Given this list of marker genes KMT2D, FGFR3, UBB, GLB1, PEX6, IPO8, TH, NEUROD2, NDUFV2, RMND1, STT3B, ACSF3 (NCBI Gene Id 197322), TSEN15, TRMT10C, B9D1, SMPD1, WNK1, TAF6 (TATA-box binding protein associated factor 6), MECP2, DHDDS, LIFR, SCNN1G, DHX30, PIGT, COG1, GNB1, ATP5F1A, ALDH18A1, HYLS1, TXNL4A, NEB, NKX2-1, GLE1, FOCAD (focadhesin), COL4A6, GALNT2, YARS1, DTYMK, ERCC8, TNNT1, PEX13, EPM2A, SLC38A3, CC2D2A, SUPT16H, SOX4, SON, SLC16A2, CACNA1S, OTUD5, IFIH1, POLA1, CEP120, PEX11B, SZT2, AIFM1, MTOR, NDE1, ATP1A3, IFT74, PIGB, DNM1L, ST3GAL5, SEMA3E, RAPSN, CLCN6, NUBPL, CACNA1I, NDUFS4, SEC24C, MOCS2, DLX4, NUS1, GCDH, EN1, GABRD, PRKCZ, MID1, COX8A (NCBI Gene Id 1351), KCNA1, TPO, GCSH, NFE2L2, COG7, PNPT1, PAFAH1B1, DDX3X, MMAA, SUZ12, NDUFB11, ZNF148, GDNF (NCBI Gene Id 2668), CWC27, ATP10A, CDH1, ASAH1, SEC63, MIPEP, SCN1B, ACTN2, LAGE3, ABCC6, USP9X, CHD8, KCNAB2, LMOD3, COLQ, NDUFS6, ARX, PEX19, CTBP1, GUF1, MGAT2, PDPN, KCNC2, FOXP3, TSPOAP1, PHOX2B, DCHS1, PAX8, PDGFRA, COX11, NDUFA6, SLC9A6, SUFU, ALG14, YWHAG, GGPS1, MYT1L, POMT2, FBXO28, ZIC2, ENPP1, CHRND (cholinergic receptor nicotinic delta subunit), SIX3, SOS1, FLI1, AASS, BTD, LIAS (NCBI Gene Id 94182), HS2ST1, HIVEP2, COL6A1, TSEN54, TOPORS, DYNC2LI1, TELO2, CYFIP2, CDC6, IFT80, TGIF1, STX3, KCNK9, AAAS (NCBI Gene Id 8086), ZNF668, SMARCB1, LRP5, SMARCD1, CARS1, ODC1, ARHGAP29, UBA2, GABRA5, NR2F1, EIF5A, VPS50, TXN2, MRPL3, RELN, SYNE1, SLC5A5, TBCD, NKX2-5, MPV17, GATA6, CNOT3, BLM, KDM3B, ZMYM2, UGDH, CDK19, PIGG, KDM5B, ETHE1, TTC21B, KCNQ5, SLC32A1, KRT16, MAP3K7, PRKAG2, SLC6A8, ZBTB18, ABCC8, AARS1, RPL10, UBTF, RECQL4, COL1A1, CREBBP, HECW2, VPS51, SIM1, MAMLD1, NFU1, PSPH, OCRL, POLR1C (NCBI Gene Id 9533), DEF6, TIMM22, PTS, UBE3A, PKHD1, DST, CEP104, COLEC10, DLK1, HERC2, LTBP4, PACS1, PIGY, RAI1, SLC7A7, HSPG2 (heparan sulfate proteoglycan 2), RPGRIP1L, CDKN1C, MMP23B, CHMP1A, ITPR1, MTM1, LRPPRC, PTCH1, KMT5B, SLC25A24, CSNK2A1, SCN8A, DPYSL5, BPTF, ZNF699, ATP6V1A, ASPA, KMT2B, H4C5, FOXG1, NDUFAF5, SLC25A22, AP3B2, MTRR, FCSK (NCBI Gene Id 197258), NEUROG1, TUBB3, LUZP1, WDR73, ANTXR2, PEX14, RET, TBCK, GRM7, PGAP1, PIK3CD, NDN, FBXW7, EDN3, FZR1, NAA20 (N-alpha-acetyltransferase 20, NatB catalytic subunit), LAMA2, SLC35B2, ASL, TET3, SUCLG1, HSD17B4, DPYD, MYH8, HDAC8, TASP1, ITPA, RRAS2 (NCBI Gene Id 22800), KCNK4, NDUFA11, SLC25A15, COX16, GRIA4, TCEAL1, SOX9, PRIM1, KIF15 (NCBI Gene Id 56992), ATP1A2, MN1, POLR1D, PPP1R21, PGAP3, POLR2A, SRP54, SSR4, APC2, MMAB, EXOSC9, ALG12, ADAMTS3, SYT1, NAGS (N-acetylglutamate synthase), ASH1L, RAF1, ADAT3, CCDC47, COG5, SMC3, GABRB2, HTRA2, FOXE1, KAT6A, TRAPPC11, AARS2, PRKG2, GLRX5, ARSL, COG4, SLC1A2, ARID1A, GTPBP3, STAG2, RNU4ATAC, SCO2, SERAC1, CLCN1 (NCBI Gene Id 1180), FZD2, UFC1, CDK13, DPAGT1, ADA2, IER3IP1, CENPT, RPS6KA3, MRAS, SLC25A46, SIGMAR1, STAC3, GRHL3, DNM1, HMGA2 (high mobility group AT-hook 2), CPT1A, DCX, TSHB, PPP2R1A, ORC1, TRRAP, NDUFA2, TOE1, ARL13B, MMUT, FAT4, RAB3GAP2, IDUA, PRDX1, CASK, BCOR, KCNQ2, NRAS, ACTL6B, KLHL41, PWRN1, HIBCH, RNF13, FOXP1, KCNB1, NSUN2, FUS, RNASEH1, COQ4, NDUFB9, GSX2, TMEM67, FARSB, SMARCC2, AUTS2, AP3D1, SH2B1, PABPN1, ACADS, SNRPN, NONO, DHX9, ADARB1, CTNS, FGF8, GRIN2B, EDNRB, FARSA, IDH1, ERCC5, CAMLG, NECTIN1, IFT140, CHD7, SRPX2, ELP1, FARS2, OTX2, TPR, SLC6A3, GMPPB (NCBI Gene Id 29925), LHX1, POLR1B, PEX16, MMACHC, CLPB, CAMK2B, AFF4, IYD, NR4A2, POMK, PPP2CA, PEX12, YIF1B, DOHH, B3GLCT, GABBR2, MYL2, EXOSC5, PEX26, UBE4B, PIGL, AGO1, MTRFR (mitochondrial translation release factor in rescue), GNAI3, DEPDC5, SRRM2, MYPN, CRLF1, PSMC1, HNRNPC, B3GALT6, MRPS34, AGTPBP1, EDEM3, CDT1, GFPT1 (NCBI Gene Id 2673), PET100, KIF5A, ISCA1, NHLRC2, HADHB, SAMHD1, NTNG1, ASXL3, CYP11B2, NDUFS1, NAA80, HIRA, TSFM, INPP5E, SYNJ1, DBR1, MT-TE, SUCLA2, CHRNE, FAM149B1, PLXND1, ANAPC1, PIGV (phosphatidylinositol glycan anchor biosynthesis class V), CA12, SET, SDHB, NELFA, RAC3, MYH3, NLRC4, ORC4, TOP3A, GLI2, IL17RC, DLD, UQCC3, STIL, GEMIN4, TRAF7, AGRN, TOGARAM1, TRMT5, MBTPS2, CLCNKB, BCKDK, TLK2, GCH1, SPRED2, PEX5, RAB11B, LIPT2, DPF2, HADHA, TALDO1, WASF1, PTPN23, DGUOK, TCF4, CTCF, MTR, TPM2, PIGQ, RASA2, EARS2, RERE, KBTBD13, SLC5A6 (NCBI Gene Id 8884), SARS2 (seryl-tRNA synthetase 2, mitochondrial), ZNF292, PIGW, MCCC2, TGFB1, PIGS, PSMD12, KRT14, NDUFAF8 (NADH:ubiquinone oxidoreductase complex assembly factor 8), SPOP, RIC1, GABRA2, MTHFS, PRDM16, SHANK3, SMC1A, KCNA2, MED12L, POT1, CAVIN1, ATP6V0A1, ERCC2, UFM1, ALS2, SLC13A5, FGFR1, GTF2H5, HDAC4, BUB1B, TBC1D24, SYT2, DISP1, GABRG2 (gamma-aminobutyric acid type A receptor subunit gamma2), PDP1, NDUFS3, ATP6V1E1, SIN3A, CAV1, FGFR2, OCA2, PIGN, SPTLC1, CEP295, YY1, TSEN2, NPHP1, SIK1, PCGF2, CHRNA1, PDHA1, SYNGAP1, NADK2, AVPR2, HNRNPH1, EHMT1, GOSR2, RARS1, DZIP1L, USP7, MFF, SETD2, CRIPTO, SDHAF1, NPAP1, NDUFAF3, PRKCSH, PPP3CA, SLC16A1, DEAF1, MRPS16, PLVAP, CCDC22, CBL, DPYS, KATNIP (katanin interacting protein), LYRM4, MYMK, ERBB2, SEPSECS, SCN9A, FANCL, TBK1, MYL1, KCNJ11, HRAS, ZNF462, GRB10, ADGRG1, NDUFAF1, PMPCB, ATRX, POLD3, MOCS1, CFL2, ACADVL, RNF6, DPM2, ACTG1, SLC30A9, RNASEH2A, OTC, CNKSR2, AHDC1, FLCN, EPB41L1, COX10, CDC45, DHCR7, SCN1A, TGFBR2, CUL3, KRT6B, CRELD1, RYR1, PIGO, TG, UNC45B, SOS2, SLC35A2, DNAJC21, PLAA, LZTR1, QRICH1, FOXP2, PLPBP, PDE10A, ATG7, NSMCE3, SIK3, ANKRD17, NEPRO, CNTN1, FKBP14, MKRN3, LTBP1, FGF12, KNSTRN, KIF1A (NCBI Gene Id 654843), SDHD, TRIO, ALG8, CDKL5, CLP1, POMT1, LBX1, NECAP1, NDUFA1, PCCB, SLC46A1, ARHGEF38, TRMU, KRT5, FOXH1, MACF1, IL17F, ARVCF, SREBF1, SLF2, GNAI1, TFG, WAC, NR3C2, ATAD3A, ACTA1, NFIX, DALRD3, ASNS, COX7B, STT3A, PUF60, FGF10, DYNC2I2, ATPAF2, NACC1, SLC25A19, RPS28, SMARCA2, TMEM231, CCDC88A, KIF7, MSX1, GPT2, SRCAP, MAP2K1, NUDT2, LETM1, UBE3C, CBY1, OTUD6B, ATP6V0A2 (NCBI Gene Id 7854), SCYL2 (NCBI Gene Id 55681), NDUFB10, PRUNE1, MAGEL2, PCCA, ACY1, DLAT, TP53RK, AGO2, EXOSC8, CACNA1B, UGP2, GET3, CACNA1A, DPH5, KAT6B, MARS1, LARGE1, EDN1, CSPP1, TRIM8 (tripartite motif containing 8), NEXMIF, CHAMP1, HACD1, MAP3K20, LMNB1, ERBB3, WDR26, PLCH1, SLC12A2 (NCBI Gene Id 6558), SCO1, SMARCE1, TUBB6, ALDH7A1 (aldehyde dehydrogenase 7 family member A1), FTH1, ZC4H2, MSL3, FBLN5, CLN8, SEMA3D, CPSF3, RAB3GAP1, COQ9, GPHN, MICOS13 (mitochondrial contact site and cristae organizing system subunit 13), MED17, BRAT1, ZBTB7A, MTHFR, PRMT7, CHRNB1, BICD2, RAP1B (RAP1B, member of RAS oncogene family), CELF2, FLNA, ADNP, TOM1, FBN1, FKTN, IVD, EMG1, FBXL4, IQSEC2, CLCNKA, TIMMDC1, EFTUD2, MARS2, SCNN1B, ANKRD11, MYO1H, SLC5A7, CPLX1, GALC, TCTN2, ALG11, COBLL1 (NCBI Gene Id 22837), FIG4, SLC9A3, CLCN3, PPM1D, FBXO11, TBX1, TCF20, MRPL39, CLCF1, SPEN, HK1, EXT2, GRIA1, CDON, SKI, PPFIBP1, SNORD115-1 (NCBI Gene Id 338433), CPT2, PHIP (NCBI Gene Id 83843), ANK1, SLC18A3, ASXL2, CPLANE1, RAD21 (RAD21 cohesin complex component), TBL1XR1, HCCS, SHQ1, IKBKG (NCBI Gene Id 8517), GFM1, CLTC, FOXRED1, CHKA, RRM2B, STRADA, UQCRFS1, RALGAPA1, ARL3, MDH2, DHCR24, KATNB1, PRORP, HESX1, SNIP1, SCNN1A, CARS2, FLAD1, EXOSC3, LHX3, TANGO2, ALG13, GLRA2, SLC12A6, ARID2, HOXB1, SOX5, KRAS, FDFT1, GNPTAB, CLDN16, CHAT, SCN3A, PAX2, DDX59, PACS2 (phosphofurin acidic cluster sorting protein 2), COX6B1, PNPO, COX15, H1-4, MBD5, TRAF3IP2, TRAK1, ARV1, SLC52A1, NDUFS8, OPA1, ZNHIT3, PI4KA, CLCN4, NUP214, NFASC, DYNC2H1, SLC25A1, JMJD1C, TMEM126B, AIMP2, EPG5, CHD3, KIAA0753, ALG2 (NCBI Gene Id 85365), MECR, GSC, ABCD1, SNRPB, UBE3B, COMT, TREX1, H19, ERGIC1, MT-ND2, WDR19, ARSA, GALK1, RTL1, HIKESHI, HNF1B, DMPK, SETBP1, ANKH, GAS1, MED23, ATP7A, PBX1, BCKDHB, SLC1A4, MCCC1, PHF6, VPS4A, PHGDH, NODAL, IBA57, PYCR2, GP1BB, TSEN34, BCS1L, TK2, PLAG1, DDX6, GFM2, EEF1A2, MT-TL1 (mitochondrially encoded tRNA-Leu (UUA/G) 1), UNC80, BIN1, AQP2, OFD1, PDE6D, EP300, SPTBN4, DUOXA2, ZSWIM6, KDM6A, RNU4-2 (RNA, U4 small nuclear 2), ECHS1, TSHR, BRPF1, TAF4, WWOX, TSPYL1, GNS, WBP4 (WW domain binding protein 4), GATAD2B, DYNC2I1, HPCA, NDUFAF4 (NCBI Gene Id 29078), LONP1, CNTNAP2, UCP2, MED12, PSAT1, ADCY6, ECE1, PROP1, MPDU1, MEIS2, ASXL1, PDSS2, NAA10, DHFR, PLA2G6, DMXL2, POLR3A, PTCD3, ATP6V1B2, MYO9A (myosin IXA), PRPS1, SHOC2, KLHL40, NIPBL, KLHL7, EPRS1, TMEM216, SPTBN1, C2CD3, ABCD4, MEG3, VPS13B, MAP2K2, PANK2, TEFM, NAA15, HADH, NTRK1, IREB2, DUOX2, SLC26A4, SMARCA4, NRCAM, DEGS1, TOR1A, NDUFS7, ANO1, SPG11, RREB1, TMEM237, ALDH6A1, NOVA2, HLCS (NCBI Gene Id 3141), TCTN1, NDUFS2, PNKP, GMNN, CASR, BMP4, DLG1, KRT6A, FBP2, PEX10, PIGU, MOGS, FRA10AC1, CDK8, CYP11A1, SDHA, NHLRC1, ZMIZ1, UBAP2L, ADAR, DLEC1, LMNA, BCKDHA, LINGO1, RRAGC, KRT17, SOX11, FUT8, SCN2A, PEX2 (NCBI Gene Id 5828, peroxisomal biogenesis factor 2), GAA, PLP1, TMEM106B, NDUFV1, PEX3, CTNNB1, PIGP, AP1S2, SATB2, RLIM (ring finger protein, LIM domain interacting, NCBI Gene Id 51132), SH3BP2, POLE, FKRP, SELENON, KMT2E, BCL11B, RARS2, DPP9, RETREG1, TCTN3, IARS1, UFD1, NTRK2, CISD2, UBA1, HBB, BSND, CRLS1, PURA, HNRNPR, RFT1, COL25A1, SNORD116-1, PLCB4, CLEC7A, CNOT2, TRIP4, KMT2A, ERCC1, PGAP2 (post-GPI attachment to proteins 2), PREPL, ALDH4A1, ORC6, POGZ, NAPB, PRKD1, PIBF1, CASZ1, ARMC9, EZH2, PTPN11, PMM2, VPS35L, SEMA3C, RNU7-1, KANSL1, CNP, LAMB2, DPM1, WARS2, BRD4 (NCBI Gene Id 90616), NSD1, HNRNPA2B1, TBC1D20, ZFX, NSD2, GALT, TPM3, PPP1CB, DYRK1A, COQ7, SCAF4, COL13A1, RNH1, DLL1, ITCH, HNRNPK, TMEM218, CLTCL1, MT-ND1, MKS1, ARCN1, TAOK1, NALCN, NDUFB3, BAP1, HNF1A, MED27, TRPV6, ABAT, SETD1A, FLII, HCN1 (hyperpolarization activated cyclic nucleotide gated potassium channel 1), ARID1B, KDM5A, MT-ND3, AHI1, SHH, ELN, GRIN2D, TP63 (NCBI Gene Id 8860), STAG1, RAC1 (NCBI Gene Id 5879), SNAP25, SETD5, NRXN1, POLR1A, RIT1, LMBRD1, POU1F1, RNF2, NRTN, SLITRK2, SNX10, LHX4, ERCC6, CEP41, LRP4, GBA1, NFKBIA, ACTB, AFG2A, TNPO2, MEF2C, TMCO1, EIF4A2, NDUFAF2, KIAA0586, H4C9, IL17RA, SCN4A, UQCRC2, PEX1, GOT2, VRK1, IGF2, GNAO1, GNB2, PQBP1, WDPCP, BICRA, PWAR1, RHBDF2, HS6ST2, POLR3K, MTO1, COL4A5, PIEZO2, COL7A1, NEDD4L, ALG6, ATXN7, GMPPA, PARS2, NARS2, MLXIPL, KAT8, ITGA7, BRAF (NCBI Gene Id 673), CAMSAP1, CDC42BPB, TRAPPC4 (trafficking protein particle complex subunit 4), HNRNPH2, TCOF1, EIF4A3, SMO, B9D2, NCAPG2, THOC2, CCDC32, UBA5, KDM1A (NCBI Gene Id 23028), HSPD1, WFS1, SNF8, HTT, LIG4, EBF3, DDC, IFT172, PI4K2A (NCBI Gene Id 55361), COL2A1, H4C3, GRIN1, ALG3, TRAPPC12, REV3L, IRF6, ESAM, CACNA2D1, FRMD5, VAMP1, PSAP, RRAS (NCBI Gene Id 6237), WASHC5 (WASH complex subunit 5), here is a description of the gene set: species: Homo sapiens Human Gene Set: HP_FEEDING_DIFFICULTIES Impaired ability to eat related to problems gathering food and getting ready to suck, chew, or swallow it. Feeding difficulties